The following is a description of a gene set: Regulation of TP53 Activity through Methylation studied in species Homo sapiens Human Gene Set: REACTOME_REGULATION_OF_TP53_ACTIVITY_THROUGH_METHYLATION, and this is the list of marker genes: MDM2, PRMT5, SMYD2, UBC, TTC5, TP53, UBB, RPS27A, UBA52, ATM, L3MBTL1, MDM4, EHMT1, KMT5A, EHMT2, JMY, EP300, CHEK2, SETD9 (SET domain containing 9)